Given this list of marker genes DCT, TYR, HSD17B1, DDT, HSD17B4, SRD5A2, HSD17B7, UGT2B15, UGT2B4, CYP11B2 (NCBI Gene Id 1585), TYRP1, UGT2B10, SULT1E1, HSD11B1, N6AMT1 (NCBI Gene Id 29104), UGT2B7, here is a description of the gene set: Human Gene Set: MODULE_505 species: Homo sapiens Steroid hormone and heme metabolism.